The following is a description of a gene set: species: Mus musculus Mouse Gene Set: REACTOME_CROSS_PRESENTATION_OF_PARTICULATE_EXOGENOUS_ANTIGENS_PHAGOSOMES Cross-presentation of particulate exogenous antigens (phagosomes), and this is the list of marker genes: Cyba, Ncf1 (NCBI Gene Id 17969), Cybb, Ncf4, Itgav, Cd36, Ncf2